The following is a description of a gene set: Mouse Gene Set: GOBP_CENTRAL_NERVOUS_SYSTEM_PROJECTION_NEURON_AXONOGENESIS Generation of a long process of a CNS neuron, that carries efferent (outgoing) action potentials from the cell body towards target cells in a different central nervous system region. species: Mus musculus, and this is the list of marker genes: Pafah1b1, Ephb1, Chrnb2, Mycbp2, Sptbn4, Draxin, Nfib, Grcc10, Zeb2, Kifbp, Wdr47, Gli2, Scn1b, Prdm8, Szt2, Ephb3, Plxna4 (NCBI Gene Id 330281), Tsku, Spg11, Nr2e1, Cdh11, Slit2, Bhlhe22 (NCBI Gene Id 59058), Adarb1, Dcx, Ephb2, Nr4a2, Epha4, Fbxo45, Nin, Dcc, Dclk1